The following is a description of a gene set: Small nuclear ribonucleoproteins (snRNPs) are crucial for pre-mRNA processing to mRNAs. Each snRNP contains a small nuclear RNA (snRNA) and an extremely stable core of seven Sm proteins. The U6 snRNA differs from the other snRNAs; it binds seven Sm-like proteins and its assembly does not involve a cytoplasmic phase. The snRNP biogenesis pathway for all of the other snRNAs is complex, involving nuclear export of snRNA, Sm-core assembly in the cytoplasm and re-import of the mature snRNP. The assembly of the snRNA:Sm-core is carried out by the survival of motor neurons (SMN) complex. The SMN complex stringently scrutinizes RNAs for specific features that define them as snRNAs and binds the RNA-binding Sm proteins. part of: Metabolism of non-coding RNA Reactome Pathway: snRNP Assembly species: Homo sapiens, and this is the list of marker genes: NCBP1, SNRPE, NUP37, DDX20, NUP50, TPR, NUP133, NDC1, GEMIN8, NUP62, GEMIN6, NUP210, NUP43, POM121C, WDR77, NUP153, SNUPN, TGS1, NUP155, PHAX, RAE1 (ribonucleic acid export 1), NUP85, NUP98, NUP35, NUP93, SNRPF, POM121, SNRPD2, NUP88, PRMT5, SEH1L, SNRPD1, NUP107, NUP188, NUP58, NCBP2, NUP205, NUP214, GEMIN5, SEC13, SNRPD3, GEMIN4, SNRPB, AAAS, SNRPG (NCBI Gene Id 6637), RANBP2, CLNS1A, NUP160, GEMIN7, SMN1, GEMIN2, rep, NUP54, NUP42